Given this list of marker genes RNF139, ZNF418, SHH, SOCS5, MAP1A, TLK2, PRKN, PSMC1, LATS1, UBE3A, RHBDF1, F8A2, PYHIN1, UBQLN2, SIRT1, WNT1, HAMP, ARHGAP5-AS1 (ARHGAP5 antisense RNA 1 (head to head)), CLU, CCAR2, KCNE2, TRIB3, GIPC1, OPHN1, APOE, TAF9, RFPL1, FZR1, UBQLN3, MDM2, DAB2, TMEM168, PSME3, PITHD1, ATP5IF1, LRRK2, AQP11, CCDC22, F8A1, UBQLN4, PSEN1, UBE2K, FBXW7, CAV1, ELOB, USP5, KLHL40, FMR1, CDC20, FBXO22, IL33, PABIR1, ALAD, PSMC6, SENP1, PRICKLE1, PLK1, SVIP, CSNK1E, TTC36, USP13, EFNA1, PRKACA, SGTA, TRIB2, PSMC2, NKD2, PABPN1L, BAG6, PSME2, SOCS4, CBFA2T3, USP38, GBA1, TGFB1I1, TMF1 (NCBI Gene Id 7110), NOP53, RPL5, ARAF, PSMC3 (proteasome 26S subunit, ATPase 3), NEURL3, PLK3, PINK1, ZER1, RNFT2, SMURF1, TAF1, CHFR, NUPR1, AURKA, IKBKG, SIRT6 (NCBI Gene Id 51548), HSPBP1 (NCBI Gene Id 29987), TF, TRIM67, PTK2, EGF, PSMD10, TRAF7, DESI1, CSNK2A2, RPS7 (NCBI Gene Id 6201), BAG5, SMAD7, ECSCR, ATXN3L, QRICH2, FBXW8, EIF3H, GSK3B, LAMP3, MIR128-1, SUMO2 (NCBI Gene Id 6613), UBXN2A (NCBI Gene Id 165324), USP19, GNA12, RCHY1, FHIT, USP26 (ubiquitin specific peptidase 26), GABARAP (GABA type A receptor-associated protein), SH3RF3, CEBPA, PHF20L1, RNF185, GCLC, DNAAF4, PSMD14, AXIN1, FOXF2, PAQR3, DNAJB2, HERPUD1, COMMD1, MARCHF7, OSBPL7, CAV3 (NCBI Gene Id 859), DDRGK1, NUDT15, RAD23B, N4BP1, NFE2L1, UCHL5, RBX1 (ring-box 1, NCBI Gene Id 9978), CSNK2B, DAB2IP, PBK, UFSP2, GSK3A, PARK7, L3MBTL3, GPX1, USP14, PSME1, CDK2, SIRT2, DDA1, DET1, TMEM259, HFE, LAPTM5, CSNK2A1, XBP1, TREM2, PRKCG, HSP90AB1, USP25, STYX, PTEN, RNFT1, NUB1, RNF180, EPHA4 (NCBI Gene Id 401031), WNT10B, COP1, CAMLG, UBXN1, RACK1, EPM2A, SUFU, RPL23, AXIN2, PRMT6, MTOR, UFL1, CDKN2A, PML, TRIM39, SUMO1, HSPA1B, STUB1, TRIB1, BBS7, CSNK1D, MAPK9, PKD1, F8A3, PSMF1, AKT1, BAG2, CDC20B (NCBI Gene Id 166979), SH3RF1, TMTC3, AGTPBP1, PANO1, WAC, MTM1, BCAP31, BTRC (beta-transducin repeat containing E3 ubiquitin protein ligase), KEAP1, HSPA1A, HECTD1, PSMC4, WFS1, AGBL4, USP9X, SMARCC1, ZYG11B, PSMC5, DVL1, CSNK1A1 (casein kinase 1 alpha 1), RYBP, GABARAPL2, PIAS1, RAD23A, SH3RF2, CTSC, USP7, DISC1, TMX1, ZFAND2A, CDK5RAP3, RPL11, NFE2L2, HIPK2, UBB, GLMN, ATXN3 (ataxin 3), PSME3IP1, VCP, PDCL3, OGT, XPO1, UBQLN1, PTK2B, here is a description of the gene set: Human Gene Set: GOBP_REGULATION_OF_PROTEOLYSIS_INVOLVED_IN_PROTEIN_CATABOLIC_PROCESS Any process that modulates the frequency, rate or extent of proteolysis involved in cellular catabolic process. studied in species Homo sapiens